Given this list of marker genes DAB1, NOTCH1, NR2E1, MYCN, MIR181B1, ID4, SERPINE2, MIR142, IL6, NOG, MAG, SHH, LDLR, HES5, NTRK3, IL6ST, BIN1, EPHA4, CNTN2, CLCF1, F2, MIR181C, NF1, NR1D1, BMP2, TTBK1, QKI (QKI, KH domain containing RNA binding), TREM2, HMGA2, ID2, HES1, LIF, GPR37L1, here is a description of the gene set: Human Gene Set: GOBP_REGULATION_OF_ASTROCYTE_DIFFERENTIATION Any process that modulates the frequency, rate or extent of astrocyte differentiation. species: Homo sapiens